Given this list of marker genes Ecd, Foxp3, Ets1, Creb1, Trim68, Kansl1, Gli3, Mtf1, Cited2, Stat1, Bcas3, Med1, Nr4a3, Cebpb, Kansl1l, Taf7, Sp1, Msx3, Pla2g4a, Pax6, Egr1, Kat2b, Eid1, Zbtb7a, Trip4 (thyroid hormone receptor interactor 4), Mef2a, Nr3c2, Sirt2, Myocd, Pcna, here is a description of the gene set: Mouse Gene Set: GOMF_HISTONE_ACETYLTRANSFERASE_BINDING Binding to an histone acetyltransferase. species: Mus musculus